The following is a description of a gene set: studied in species Homo sapiens Pathway Definition from KEGG: Tir -> SHP1/2 -| (TRAF6+TAK1+TAB2) Human Gene Set: KEGG_MEDICUS_PATHOGEN_ESCHERICHIA_TIR_TO_TLR2_4_MAPK_SIGNALING_PATHWAY Escherichia Tir to TLR2/4-MAPK signaling pathway. Pathway ID: N00926. Pathway type: Pathogen. Pathway class: nt06517 TLR signaling., and this is the list of marker genes: MAP3K7, TRAF6, PTPN6, TAB2, PTPN11